Given this list of marker genes Cd9, Cyba, Apoc2, Wfdc17, Rps3, Psmb6, Fth1, Ptpn1, Mrps24, Ndufb9, Rgs2, Jchain, Prdx2, H2-Aa, Psmb4, Rpl3, Mdh2, Nme2, Lcn2, Trem2, Psmb2, Rbm3, Rpl8, Atp5if1, Tmem176b, Erh, Pycard, Rps9 (NCBI Gene Id 76846), Apoe, Ms4a6d, Ifitm6, Malat1, Dmkn, Pim1, Hp, S100a8, Rpl9, Rps2, Pglyrp1, H2-K1, Ngp, Mrpl54, S100a9, Gngt2, Prtn3, Ctsl (cathepsin L), Calr, Nedd8, Nupr1, H2-DMb1, Scand1, Retnlg (resistin like gamma), AW112010, Rpl13, Tmed9, Rpl6, Rps3a1, Rpl11, Prr13, Rps27a, Rps6, Chmp2a, Calm1, Tmem176a, Atp5mc1, Ldha, Selenos, Ifi30, Camp, Rpl14, Cd24a, Psmb8, Cox5a, Wfdc21, Ifitm2, Tbcb, Srgn, Spi1, Rpl13a, Nme1, Mrpl20, Park7, Cirbp, Cd74, Ltf, Etfb (NCBI Gene Id 72756), Cfl1, Map1lc3b, Rps18, H2-Ab1, Phb2, Mif, Tmem160 (NCBI Gene Id 69094), Serpinb1a, here is a description of the gene set: Mouse Gene Set: TABULA_MURIS_SENIS_MARROW_PROMONOCYTE_AGEING species: Mus musculus from publication Tabula Muris Consortium (PMID 32669714)